The following is a description of a gene set: studied in species Homo sapiens from publication Jiang C, Chao CC, Li J, Ge X, Shen A, Jucaud V, Cheng C, Shen X (PMID 38455971) Tissue-resident memory T cells (TRM) are a specialized T cell population residing in peripheral tissues. The presence and potential impact of TRM in the tumor immune microenvironment (TIME) remain to be elucidated. Here, we systematically investigated the relationship between TRM and melanoma TIME based on multiple clinical single-cell RNA-seq datasets and developed signatures indicative of TRM infiltration. TRM infiltration is associated with longer overall survival and abundance of T cells, NK cells, M1 macrophages, and memory B cells in the TIME. A 22-gene TRM derived risk score was further developed to effectively classify patients into low- and high-risk categories, distinguishing overall survival and immune activation, particularly in T cell-mediated responses. Altogether, our analysis suggests that TRM abundance is associated with melanoma TIME activation and patient survival, and the TRM-based machine learning model can potentially predict prognosis in melanoma patients. This gene set comprises a 22-gene signature derived from tissue-resident memory T cells (TRM) specifically associated with improved prognosis in melanoma patients. Enrichment of this signature in the tumor immune microenvironment (TIME) correlates with heightened immune activation, particularly involving T cells, NK cells, and M1 macrophages. High TRM infiltration is linked with longer overall survival and a more robust immune response. This signature enables stratification of melanoma patients into low- and high-risk categories, providing significant prognostic insights and aiding in the prediction of patient outcomes. Human Gene Set: JIANG_MELANOMA_TRM_HIGH_SURVIVAL_22_GENE_SIGNATURE, and this is the list of marker genes: SLC25A12, HSPB6, IFITM1, CAMK4, PRG2, PRKAR2B, GIMAP2, TMBIM6, HAPLN3, MKI67, CTBS, CD33, NCCRP1, KPNA2, HSPA2, HSPA7, HCP5, BCAS4, NOTCH3, TTC39C, NCL, CCT6B